Given this list of marker genes Nlrp1b, Rock2, Psmd14, Aph1c (NCBI Gene Id 68318), Ncstn, Lgmn, Hspd1, Nlrp3, Adrm1b, Bad, Psme1, Nlrc4, Sfrp2, Malt1, Timm50, Psme2, Psme3 (proteaseome (prosome, macropain) activator subunit 3 (PA28 gamma, Ki)), Elp2, Vsir, Psenen (presenilin enhancer gamma secretase subunit), Adrm1, Aph1b, Nlrp1a, Aph1a, Aim2, Pycard, here is a description of the gene set: Mouse Gene Set: GOMF_ENDOPEPTIDASE_ACTIVATOR_ACTIVITY studied in species Mus musculus Binds to and increases the activity of an endopeptidase.